Given this list of marker genes Mapk14, Dusp7, Rps6ka5, Dusp6, Mapk7, Ppp2r1b, Vrk3, Mapk11, Mapk3, Ppp2r5d, here is a description of the gene set: studied in species Mus musculus Reactome Pathway: ERK/MAPK targets part of: MAPK targets/ Nuclear events mediated by MAP kinases; Nuclear Events (kinase and transcription factor activation) electronically inferred by orthology from the curated human pathway This event has been computationally inferred from an event that has been demonstrated in another species.<p>The inference is based on the homology mapping from PANTHER. Briefly, reactions for which all involved PhysicalEntities (in input, output and catalyst) have a mapped orthologue/paralogue (for complexes at least 75% of components must have a mapping) are inferred to the other species.